Given this list of marker genes DDB2, WDR77, DDB1, RBX1, DTL (denticleless E3 ubiquitin protein ligase homolog), CUL4B, here is a description of the gene set: A ubiquitin ligase complex in which a cullin from the Cul4B subfamily and a RING domain protein form the catalytic core; substrate specificity is conferred by unknown subunits. species: Homo sapiens Human Gene Set: GOCC_CUL4B_RING_E3_UBIQUITIN_LIGASE_COMPLEX